The following is a description of a gene set: species: Homo sapiens Abnormal fingernail morphology An abnormality of the fingernails. Human Gene Set: HP_ABNORMAL_FINGERNAIL_MORPHOLOGY, and this is the list of marker genes: LMNA, NSD1, IL17F, GTF2E2, RNF113A, WNT5A, LIMK1, EOGT, WRAP53, TWIST2, COL7A1, GNA11, PRKACB, DKC1, TBC1D24, IL17RA, TP63, CENPT, ARID2, FKBP6, PEX6, ARID1A, PEPD, HPGD, PIGN, ZMPSTE24, MAP2K1, MBTPS2, PITX1, GTF2IRD1, ATP6V1B2, BAZ1B, TRAF6, TMEM270, HYMAI, SMARCD1, COL11A1, DPF2 (double PHD fingers 2), USB1, NPM1, KCNH1, KRT6B, GTF2I, EVC2, CTSC (NCBI Gene Id 50958), TET2, DPYSL5, SHOX, NSUN2, EVC, TFAP2A, WDR35, KRT74, SMARCB1, KDF1, MSX1, INPPL1, CLIP2, PLAG1, POFUT1, RTEL1, SMARCE1, MPLKIP, TBX3, DYNC2LI1, KRT9, SUZ12, PPP1CB, MAP2K2, TERT, NHP2, KRT1, CDKN1C (NCBI Gene Id 702), GDF5, ERI1 (NCBI Gene Id 90459), RFC2, EDARADD, IFT43, CLEC7A, BRAF (NCBI Gene Id 673), GJA1, RNU12, KRT6A, BUD23, FBXO28, KRT14, RUNX2, CARS1, LMX1B, RETREG1, KRAS, ROR2, PIGO, GLI1, PAX9, PIGF, STX1A, ZBTB20, KIF1A, HRAS, DVL1, DLL4, PLAGL1, MACROH2A1, CASR, TERC (telomerase RNA component), DVL3, GTF2H5, TBL2, IFT122, WNT10A, ARID1B, SLCO2A1, POGLUT1, VPS35L, CCDC22, SLC39A4, METTL27, SOX4, NOP10, PSENEN, TRAF3IP2, SMARCA4, ERCC3, SOST, SOX11, SCN9A, PERP (p53 apoptosis effector related to PMP22), IGF2, TARS1, EFNB1, PTDSS1, TYMS, NCF1, NECTIN1, EZH2, WDR19, BMPR1B, COL11A2, DOCK6 (dedicator of cytokinesis 6), LIG4, WNK1, FGFR2, RBPJ, BMPER, WASHC5, NOTCH1, PLEC, NXN, CTC1, PGAP2, ITGB4, AARS1, AIRE (NCBI Gene Id 326), FZD2, PLCD1, SHOC2, CSTB, SLC35D1, PRKACA, IL11RA, GTF2IRD2, EDAR, IL17RC, KRT17, ERCC2 (ERCC excision repair 2, TFIIH core complex helicase subunit), LRP4, SF3B1, PEX1, HMGA2, DNAJC30, ZNF462, KRT5, SMARCC2, ARHGAP31, IFT52, EIF4H, AFF4, KCTD1, STAT3, COL17A1, ELN, KRT16, HLA-B, PARN, IKBKG, HOXC13, KCNN3, NOTCH2, TINF2, PKP1, VPS37D, TRPV3, RPS6KA3